Given this list of marker genes SLC35E3, ADSS1, MEIS1, DNMT3A, VILL, RPS6KA5, SKAP2, ENTPD1, APPL1, HDAC9, FSTL1, ZBTB42, ITM2A, SLC16A13, HIVEP3, DIO2, C11orf54, TRPM4, RNF24, IFITM3, PLEKHA2, PTPRC, IFI44, AS3MT, RASGEF1B, HERC3, PAM, INTS6L (NCBI Gene Id 654032), NUDT14, ZNF397, ANGPT1, RAB37, ABCG1, HLA-DOA, CSRP2, SMAD1, INPP5A, PRXL2B, MYO1G, PRDM16, FGD1, IQGAP1, P3H3, PGK1, SH3BP5, MPO, RPS6KA3, ACVR1B, ELOVL7, ARHGAP6, MAMDC2, PRX, ARID5A (AT-rich interaction domain 5A), KAZN, NPL, VEGFC, EGLN3, SFXN4, CCNI, BTD, TRPS1, CAMK2G, DIAPH2, ALOX5AP, CDCA7L, CALCRL, ZNF467, RBP1, ELK3, IL27RA, TMEM50B, RIPOR2, CELSR1, RAB29, STING1 (NCBI Gene Id 340061), PDE8A, TLR4 (NCBI Gene Id 7099), IL11RA, C8orf58, CAMKK1, FKBP7, OAS1, MYOM1, RGS18, ALDH1L1, TMEM98, CSRNP1, CPNE3, ZNF184, INSR, CORO1A, NAPSA, CLN5, LPAR6, RCSD1, PSTPIP1, RNASE6, THTPA, PARP12, PPM1K, HOXA9 (homeobox A9), PAK1, EPSTI1, GPRASP1, DACH1, LTB, H1-0 (NCBI Gene Id 3005), MFNG, ANXA4, ACOT11, LPP, ANTXR2, C1orf54, FAH, IFT88, KANK3, NIBAN1, PCIF1, RASGRP2, SORBS3, NCF2, PANK2, FOXD2, INSL6, TEC, PTTG1IP, EXOC3L2, ARHGAP25, PLXDC2, CASP12, EVA1B, CDK18, CSNK1E, SORL1, GHR, MPND, SRC, ABHD6, PEAR1, KLHL24, SLC2A1, FBXO21, MARVELD2, HPCAL1, XBP1, FJX1, ZNF619, CEP68, SESN3, NKG7, AKAP13, CLEC11A, TNRC18, CD72, HACD4, MMP2, CACNB2, C9orf152, ITGA6, CERS5, STAT4, HEXB, ZFAND3, NLRC3, CAPN2, DOCK2, RASSF2, ST8SIA4 (NCBI Gene Id 7903), CERS6, TMEM71, TUBB6, ASB4, VANGL2, EXTL2, INSYN2A, TPD52, TP53I13, VAV1, LTBP3, ANP32A, PPP1R13B, CDKN2D, TFEC, SLC16A9, CTSG, ZFHX3, PARP11, PKM, IL18R1, DNAJB9, ETV6, AMN1, ETS1, PGLYRP2, SPATA13, GDPD3, OCRL, ZNF608, KANK2, here is a description of the gene set: Human Natural Killer (NK) cells comprise two main subsets, CD56bright and CD56dim cells, that differ in function, phenotype and tissue localization. To further dissect the heterogeneity of CD56dim cells, we have performed transcriptome analysis and functional ex vivo characterization of human NK cell subsets according to the expression of markers related to differentiation, migration or competence. Here, we show for the first time that the ability to respond to cytokines or to activating receptors is mutually exclusive in almost all NK cells with the exception of CD56dim CD62L+ cells. Indeed, only these cells combine the ability to produce interferon (IFN)-gamma after cytokines and proliferate in vivo during viral infection with the capacity to kill and produce cytokines upon engagement of activating receptors. Therefore, CD56dim CD62L+ cells represent a unique subset of polyfunctional NK cells. Ex vivo analysis of their function, phenotype, telomere length, frequencies during ageing as well as transfer experiments of NK cell subsets into immunodeficient mice suggest that CD56dim CD62L+ cells represent an intermediate stage of NK cell maturation, which after restimulation can accomplish multiple tasks and further develop into terminally differentiated effectors. from publication Juelke K, Killig M, Luetke-Eversloh M, Parente E, Gruen J, Morandi B, Ferlazzo G, Thiel A, Schmitt-Knosalla I, Romagnani C (PMID 20505160) Genes up-regulated in SELL dim NK cells: NCAM1+ versus NCAM1-. studied in species Homo sapiens Human Gene Set: GSE21774_CD62L_POS_CD56_DIM_VS_CD62L_NEG_CD56_DIM_NK_CELL_UP